Given this list of marker genes CLCN5, EFCAB9, GPS2, CAT, RHBDD2, OAS3, GSN, PI4K2B, ARSB, SLC49A4, GK5, PIP4P1, ST14, SUSD1, SCPEP1, KMO, APOC2, LIFR (LIF receptor subunit alpha), MAN1C1, STX1A, SMAP1 (small ArfGAP 1), EPPK1, UBR2, LY6D, RNF115, BBLN, DUSP3, DGKE, ATOSA, TG, MYH9, CSPG4, OAS1, ASS1, PBXIP1, CHP1, SDC4, ARHGAP18, MYO1H, ATF6, ART4, MTAP, PSAP, NATD1, CALCRL, FBXO9, S100A11, MGST2, DNAJB11, ATRNL1, CD72, SELENOP (selenoprotein P), DHX40, FAM43A, USP12, RNF125, ANXA6, GMFG, TM6SF1, GYPC, CIPC, SGTA, PLCD3, TBC1D14, PSEN1, KDM5B, CNRIP1, SLC5A5, HBG2, SLAMF9, YPEL2, ST3GAL6, LCA5L, PTGR1, NID1, LGALS9B, MYL4, PIK3CG, CRAT, CD93, ARPC2, PPP2CB, MACIR, PEDS1, TMEM9B, CFP, VPREB3, APBB2, HSPA12A, SLC39A8, ACO1, GALC, SPP1 (NCBI Gene Id 6696), SLC16A9, SAMHD1, MCOLN2, ADD3, ATXN2, BRAP, CDYL2, SPI1, FUT4, PITHD1, HECA, CHD3, GAMT, CARD6, ATP6AP1, ADAP1, AKIRIN1, AP3D1, AK3, SLCO4A1, LMO4, PALM, PSTPIP1, SMCHD1, ZMYND11, BANK1, ALDH3B1, DAB2IP, RAP2B, CORO1C (coronin 1C), IGHG1, SULT1A1, HSD17B11, RIGI (RNA sensor RIG-I), EHD2, STK40, ARHGEF15, ACSL1, COL15A1, S1PR4, CD2, PHLPP1, ASNSD1, L3MBTL3 (NCBI Gene Id 84456), L1CAM, BCL2L11, IL10RA, FAM234B, CBLB, RDX, GPR171, KLF7, RNF144A, STAT5A, TRIM25, TTYH3, ATXN1, PXDC1, ABCG2, KCTD17, FRRS1, TMEM163 (NCBI Gene Id 81615), PRNP, IFNAR2, RASGRP2, USP3, KCTD10, FNIP2, ABHD17B, NAV2, MAN2B1, TPST2, TMEM50B, IDE, WDFY2, LPAR6, SLC30A4, PIP4P2, TREML2, SMAD3, ACP5, KRAS, ADAMTSL1, CARMIL1, STAC2, DUSP4, CD36 (NCBI Gene Id 948), MKNK2, GGH, DGKA, TNRC18, SPN, MYO7A, PATJ, KCTD3, SYS1, STAT4, RSAD2, SEC16B, GPD1L, VIM, SLC44A2, PLEKHA1, TRAM2, PNPLA7, SLC66A2, PRPS2, here is a description of the gene set: Human Gene Set: GSE2770_IL12_VS_TGFB_AND_IL12_TREATED_ACT_CD4_TCELL_48H_UP from publication Lund R, Aittokallio T, Nevalainen O, Lahesmaa R (PMID 14607935) studied in species Homo sapiens Genes up-regulated in CD4 T cells activated by anti-CD3 and anti-CD28: IL-12 (48h) versus TGFB1 and IL-12 (48h). Th1 and Th2 cells arise from a common precursor cell in response to triggering through the TCR and cytokine receptors for IL-12 or IL-4. This leads to activation of complex signaling pathways, which are not known in detail. Disturbances in the balance between type 1 and type 2 responses can lead to certain immune-mediated diseases. Thus, it is important to understand how Th1 and Th2 cells are generated. To clarify the mechanisms as to how IL-12 and IL-4 induce Th1 and Th2 differentiation and how TGF-beta can inhibit this process, we have used oligonucleotide arrays to examine the early polarization of Th1 and Th2 cells in the presence and absence of TGF-beta after 0, 2, 6 and 48 hours of polarization.